The following is a description of a gene set: A myosin complex containing two class II myosin heavy chains, two myosin essential light chains and two myosin regulatory light chains. Also known as classical myosin or conventional myosin, the myosin II class includes the major muscle myosin of vertebrate and invertebrate muscle, and is characterized by alpha-helical coiled coil tails that self assemble to form a variety of filament structures. studied in species Mus musculus Mouse Gene Set: GOCC_MYOSIN_II_COMPLEX, and this is the list of marker genes: Myh2, Myh1, Limch1, Myh13, Myl12b, Myh3, Myl4, Myh11, Ttn, Myl9, Myh4, Myh14, Myh8, Myl6b, Myl6, Myo18b, Myh7, Myh15, Myh6, Myl1, Myh10, Myh9, Myo18a, Myl3, Myl12a, Myh7b